Given this list of marker genes Mapk8, Il1f10, here is a description of the gene set: This event has been computationally inferred from an event that has been demonstrated in another species.<p>The inference is based on the homology mapping from PANTHER. Briefly, reactions for which all involved PhysicalEntities (in input, output and catalyst) have a mapped orthologue/paralogue (for complexes at least 75% of components must have a mapping) are inferred to the other species. Reactome Pathway: Interleukin-38 signaling species: Mus musculus part of: Interleukin-1 family signaling electronically inferred by orthology from the curated human pathway